The following is a description of a gene set: from publication Yao MW, Lim H, Schust DJ, Choe SE, Farago A, Ding Y, Michaud S, Church GM, Maas RL (PMID 12554760) species: Mus musculus Human infertility and recurrent pregnancy loss caused by implantation defects are poorly understood. Hoxa-10-deficient female mice have severe infertility and recurrent pregnancy loss due to defective uterine implantation. Gene expression profiling experiments reveal that Hoxa-10 is an important regulator of two critical events in implantation: stromal cell proliferation and local immunosuppression. At the time of implantation, Hoxa-10 mediates the progesterone-stimulated proliferation of uterine stromal cells. Hoxa-10 mutants express a stromal cell proliferation defect that is accompanied by quantitative or spatial alterations in the expression of two cyclin-dependent kinase inhibitor genes, p57 and p15. Hoxa-10 deficiency also leads to a severe local immunological disturbance, characterized by a polyclonal proliferation of T cells, that occurs in place of the normal progesterone-mediated immunosuppression in the periimplantation uterus. Mouse Gene Set: YAO_TEMPORAL_RESPONSE_TO_PROGESTERONE_CLUSTER_3 Genes co-regulated in uterus during a time course response to progesterone: SOM cluster 3., and this is the list of marker genes: Igkv17-127, Igkv8-30, Ighv1-84, Ighv1-64, Ighv1-26, Igha, Itih1, Minpp1, Ighv1-52, Igkv8-24, Igkc, Mbtd1, Rabgap1l, Ptpn22, Ighv8-9 (NCBI Gene Id 432709), Nfkbia, Jchain, Igkv8-19, Pten, ENSMUSG00000137801, Igkv10-95, Igkv1-135, Igkv1-117, Igkv6-15, Igkv4-68, Car2, Sema3e, Gadd45a, Ighv1-83, Esr1, Ighv1-34, Ighv1-54, Ighv1-59, Hpgd, Ighv1-20, Ighv14-4, Ighv1-77